The following is a description of a gene set: Genes predicted to be targets of miRBase v22 microRNA hsa-miR-147a in miRDB v6.0 with MirTarget v4 prediction scores > 80 (high confidence targets). species: Homo sapiens from publication Chen Y, Wang X (PMID 31504780) Human Gene Set: MIR147A, and this is the list of marker genes: DCLK3, CYP27C1, MUC13, SLC25A21, MAPK6, SNRNP25, HSDL2, ZDHHC3, FDFT1, GRID1, GCFC2 (NCBI Gene Id 6936), FAM110B, ADGRA1, CYP2S1, CREBRF, KIF20A, NR3C1, NFAT5, MTX2, ST8SIA4, HDLBP, IL13RA1, ANK3, LSAMP, PTCHD4, PPM1D, SETBP1, ARL13B, LATS2, SSR1, CHMP7, TNFSF14, SEL1L, FOXP3, ZBTB4, MAP4K3, ZFX, BMP4 (NCBI Gene Id 652), ZEB2, KLF7, RAB27B, MAN2B2, TBC1D20 (TBC1 domain family member 20), PTPRK, ADIPOR2, IGF2, ZNF483 (NCBI Gene Id 158399), NFASC, ACLY, PCMT1, KCNJ3, GPD1L, BCOR, PDPK1, STPG4, IRX5, CLRN1, UBXN8, SPATS2, TNRC6B, BCL2L13, MPIG6B (NCBI Gene Id 80739), IKBIP